The following is a description of a gene set: Mouse Gene Set: GOBP_EPIDERMAL_CELL_FATE_SPECIFICATION The process in which a cell becomes capable of differentiating autonomously into an epidermal cell in an environment that is neutral with respect to the developmental pathway; upon specification, the cell fate can be reversed. species: Mus musculus, and this is the list of marker genes: Mir450b, Ptch1, Notch1, Ptch2, Foxi3, Rbpj